The following is a description of a gene set: Mouse Gene Set: RASHI_RESPONSE_TO_IONIZING_RADIATION_6 from publication Rashi-Elkeles S, Elkon R, Weizman N, Linhart C, Amariglio N, Sternberg G, Rechavi G, Barzilai A, Shamir R, Shiloh Y (PMID 16314843) Cluster 6: late responding genes activated in ATM deficient but not in the wild type tissues. The ATM protein kinase, functionally missing in patients with the human genetic disorder ataxia-telangiectasia, is a master regulator of the cellular network induced by DNA double-strand breaks. The ATM gene is also frequently mutated in sporadic cancers of lymphoid origin. Here, we applied a functional genomics approach that combined gene expression profiling and computational promoter analysis to obtain global dissection of the transcriptional response to ionizing radiation in murine lymphoid tissue. Cluster analysis revealed a prominent pattern characterizing dozens of genes whose response to irradiation was Atm-dependent. Computational analysis identified significant enrichment of the binding site signatures of NF-kappaB and p53 among promoters of these genes, pointing to the major role of these two transcription factors in mediating the Atm-dependent transcriptional response in the irradiated lymphoid tissue. Examination of the response showed that pro- and antiapoptotic signals were simultaneously induced, with the proapoptotic pathway mediated by p53 targets, and the prosurvival pathway by NF-kappaB targets. These findings further elucidate the molecular network induced by IR, point to novel putative NF-kappaB targets, and suggest a mechanistic model for cellular balancing between pro- and antiapoptotic signals induced by IR in lymphoid tissues, which has implications for cancer management. The emerging model suggests that restoring the p53-mediated apoptotic arm while blocking the NF-kappaB-mediated prosurvival arm could effectively increase the radiosensitivity of lymphoid tumors. studied in species Mus musculus, and this is the list of marker genes: Sec61a2, Ighv1-83, Nono, Rnf38, Bmal1, Slc66a3, Cxcl13, Fermt3, Slfn4, Laptm5, Cfp, Plekho1, Fas, Igkv8-30, Igkv4-68, Rhoh, Ms4a1, Maz, Ighg3, Incenp (NCBI Gene Id 98139), Ccl5, Iglv3, Csf2ra, Zfp688, Brix1, Hhex, Mcpt9, Ighg2b, Iglc2, Igkv8-19, Ighv1-84, Ccnj, Saal1, Gbp2b, Ighv1-52, Slfn1, Ighv1-59, D030056L22Rik, Igkv10-94, Igkv1-135, Ighv1-77, Tyrobp, Ash1l, Ighv14-4, Ighv1-20, Gm11973, Acin1, Aldoc, Ighv1-34, Ccl8, Mbtd1, Tcf25, Htr1d, Ikzf1, Rnase1, Igkv17-127, Saa3, Pip4k2a, Igkv12-46, Il18r1, Grk2, Cul2, Adh1, Ighv5-12, S100a8, Aldoa, Ddx52, Evi2a, Igkv1-117, Eif4ebp2, Slpi, Ifitm6, Fmnl1, Rad51ap1, Igkv10-95, Ccr2, Mrpl41, Selplg, S100a9, Ighv1-42, Fcgr2b, Ighv1-64, Il1r2, Ighv1-19, Psmb9, Ighv1-26, Ccl9, Cxcl9, Ptprc (protein tyrosine phosphatase receptor type C), Ubd, Igkv12-44, Igkv4-79, Igkv14-111, Msc, Emp3, Zfp653, Kng1, Pde7a, Ighm, Igkv4-59, Igkv4-74, Sugt1, Unc93b1, Ighg1 (immunoglobulin heavy constant gamma 1 (G1m marker)), Igkv8-24, Ighv8-9, Ifit1, Ptp4a3, Zfp97, Tmem70, Zcchc3, Cd48 (NCBI Gene Id 98728), Ighv1-54, Slc38a4, Igkv4-73, Ighv1-14, Ddx18, Bag6, Cd79b, Mir142hg, Rrp7a, Igkv6-15, Lyz2, Cxcr4, Igkv16-104